Given this list of marker genes Rs1, Plekha4, Snx24, Rubcnl, Wipi2, Plekhf1, Plek2, Wipi1, Rufy4, Pla2g4a, Rbsn, Snx12 (NCBI Gene Id 72081), Snx3, Washc2, Bbs5, Snx21, Dennd1a, Snx4, Wdr45, Plcz1, Atg2a, Hip1, Kif16b, Sap30l, Zfyve19, Plekha5, Phlda3, Zfyve1, Zfyve28, Snx27, Snx20, Ncf4, Snx13, Jph2, Dab2ip, Tecpr1, Zfyve26, Wdr45b, Lancl2, Sh3pxd2a, Vps13b, Sh3pxd2b, Sestd1, Pard3, Vps36, Obscn, Pla2g4e, Atg2b, here is a description of the gene set: Binding to phosphatidylinositol-3-phosphate, a derivative of phosphatidylinositol in which the inositol ring is phosphorylated at the 3' position. species: Mus musculus Mouse Gene Set: GOMF_PHOSPHATIDYLINOSITOL_3_PHOSPHATE_BINDING